The following is a description of a gene set: Genes in the cancer module 115. species: Homo sapiens Human Gene Set: MODULE_115, and this is the list of marker genes: EIF3B, EIF3G, EIF1, EIF4H, EIF4EBP2, EIF3E, EIF4A1, EIF4B, BZW1, EEF1A1, EIF5A (NCBI Gene Id 1984), EIF4A2, EEF2, EIF3F, PABPC1, EEF1B2, EIF3H, EIF3I, HSPB1, EIF3D, EEF1D, EIF6, EIF4EBP1 (eukaryotic translation initiation factor 4E binding protein 1), EEF1A2, EIF3C, EIF4G2, EEF1G